The following is a description of a gene set: species: Homo sapiens Human Gene Set: GOBP_PROTEIN_LOCALIZATION_TO_VACUOLE A process in which a protein is transported to, or maintained at, a location in a vacuole., and this is the list of marker genes: WASH3P, SORL1, GCC2, MVB12B, RTN4, ZFYVE16, LMBRD1, MEAK7, STAM, VPS37A, SNX16, RNF128, TSG101 (tumor susceptibility 101), RRAGC, CD81, RAB7A, VPS13D, STAM2, LAMTOR4, VPS37B (NCBI Gene Id 79720), SH3GLB1 (NCBI Gene Id 51100), AP3D1, VPS4A, MVB12A, PIK3R4, GNPTG, NEDD4, NDP, GBP1, MON1A, VPS13A, VPS37D, MON1B, GPR137B, NAGPA, BECN1, GGA3, M6PR, VPS41, KICS2, GLMP, SH3BP4, PTPN23, AP4M1, SQSTM1, SORT1, VPS37C, VPS28, VPS13C, ATG14, VPS36, VPS53, SMURF1, PIK3C3, ATP13A2 (NCBI Gene Id 63919), MFSD1, LAMTOR1, TNFAIP3, VPS8, ROCK2, LAMP2, UBAP1, GNPTAB, SNF8, AP3B1, IRGM, CLU, VPS54, UMOD, KPTN, LAMTOR5, AKT1, RRAGA, VPS25, AP3M1, HGS, SZT2, HSPA8, LAPTM5, NCOA4, SCARB2